Given this list of marker genes MTNAP1, EYA4, FREM1, RIMKLB, LAMC1, GNB4, PCLO, BCAT1, A1CF, ALDH2, C6orf62, CD36, TBL1XR1, SCN2A, GBE1, SLC16A1, ZNF644, TRIP12, KIF1B, SLC17A1, MRO, PPIC, SRP9 (NCBI Gene Id 6726), HUS1, GRM8, RELCH, MSTN, TCF12, FABP7, TMEM64, APC, CDK6, NR2F2 (NCBI Gene Id 7026), MED23, MAPK8, NUB1, ASB14, RALB, CWC27, ZMYM3, PLEKHF2, SMAD2, KLHL15, SHROOM3, USP13, GPC6, COL25A1 (collagen type XXV alpha 1 chain), SEPTIN10, TGFA, PCNX4, TMEM38B, RPRD1A, HMGCLL1, CCDC186, SGIP1, SPATA6L, DBI, ZC3H12C, JMY, NLGN1, MSANTD4, NEGR1 (NCBI Gene Id 257194), NUP54, OLA1 (NCBI Gene Id 89690), PNO1, ACVR1C, PRXL2A, VPS72, MGAT2, ZNF274, PKIA, HAPLN1 (NCBI Gene Id 1404), TPT1 (NCBI Gene Id 7178), OTUD4, TMEM167A, KCNJ2, RAPH1, VAV3, FAM20B, DUSP16, PRLR, UST, N4BP2, ZNF431, KLRC2, CCNE1, DLST, AGA, SPAG9, PERM1, SECTM1, SCN3B, TNFSF14, MYO1D, TSC22D2, PCDH11X, EML1, SLC36A4, LNPEP, SHLD1, TMX3, ZNF507, ABHD2, GEMIN2, IRAK2, GIGYF2, ZC2HC1A, COL22A1, MARK1, RUNX1, CASP1, PDHA1, PRDM5, CDKN1C, PCDHB4, MLF1, TRAPPC10, PTPRN2, P2RY13, SENP2, EXPH5, RAPGEF6, IFNK, PPM1B, CHL1, IRGQ, MMAA, SLC25A24, MGAT1, CNKSR3, C9orf57, CXADR (CXADR Ig-like cell adhesion molecule), RNGTT, FECH, COG6, SLC25A2, TEX26, WDR44, ZNF527, AZIN1, BDH2, SCOC, DDC, PLA2R1, ARL6IP6, CSNK1A1L, ERICH1, CBLN1, DYNLT1, VIRMA, DENND4A, COL3A1, LIMA1, FAM171B, CSRNP3, PIWIL4, KLHL14, C5orf15, CSGALNACT2, DACH1, VWC2, ARHGAP15, MTHFSD, PUM2, ACTA2, PLPP4, MMP16, YIPF6, SASS6, CAPN14, TNFRSF11B, RAB27B, SOCS6 (suppressor of cytokine signaling 6), MAB21L1, VPS45, BOLA2-SMG1P6, SLC35F5, ARIH1, ATG4C, ATP5PB, TRAPPC11, TTPAL, ABCC5, N4BP2L2, ZDHHC15, FANCD2, PDXDC1, MAP1A, CATSPERE, ZC3H14, ESYT2, TTC33, ZNF569, GPR158, TRMT9B, XYLT1 (xylosyltransferase 1), RMC1, MTCP1, PTGER2, DCAF12, ZKSCAN3, GFM2, DSEL, PLCL1, TRIM10, ANKRD20A1, CMC1, GATC (glutamyl-tRNA amidotransferase subunit C), RAB23, NECTIN4, ASXL1 (NCBI Gene Id 23393), ADAM10, NPR3, ZBTB33, MCTP1, DNAH14, DCUN1D4, KCNAB1, BRWD1, EVI2B, RAB11FIP2, ADAM28 (ADAM metallopeptidase domain 28), CLSTN2, MDM4, TM9SF3, SS18L1, TTC27, ATXN3, ZNF516, RNF38, RPA1, UBE2D1, SLC44A1, HEMGN, SNTG1, KATNAL1, PIKFYVE, AGPS, MEGF11, RXFP1, LYSET, TMEM215, MED13L, CERK, RFLNB, ODR4, MSL1 (MSL complex subunit 1), NIPA2, KLF12, PDCD1LG2, VSTM2A, BRWD3, LMLN, ANKRD12, TSHZ3, RALGPS2, FAM114A2, SP140L, HDX, ANKRD42, NAV1, TP53AIP1, SCN7A, ZMYM2, HOOK3, KIAA1549L, CNOT6, SCPEP1, SKIC3, ZBTB20, NCR2, SLC15A2, GAS2L3, NUDT16, ATXN1, ANKRD20A4P, FUT9, ZBTB44, CSAG3, NALCN, LBH, AAK1, TIAM1, CDH13, RAB21, PLK4, MATR3, SMG1, CPXCR1, TAFA2, WIPF1, NXPE3, ADCY9 (adenylate cyclase 9), HDAC9, OTOGL, LEPROT, INO80C, ZNF620, ITPRIPL2, SNUPN, LBR, CSAG1, RYR3, IVNS1ABP, TET2, C11orf87, CNIH1, CALML4, RSF1, STXBP5L, CEP20, EXOC8, AADAC, GLRB, ARV1, SLC19A4P, KCNS3, SIX4, ECHDC3, SLC1A1, CCDC88A, RBBP5, NANP, NECAB1, TAOK1 (NCBI Gene Id 80214), BMPR2, CCDC102B, MAPK10 (NCBI Gene Id 5602), PLPPR4, VCPIP1, TNKS, PDE7A, CDC40, RUNX1T1, MFSD4B, ANKRD20A2P, CHUK, DHX29, PCDH17, MINDY2, MOXD1, here is a description of the gene set: Human Gene Set: MIR3942_3P Genes predicted to be targets of miRBase v22 microRNA hsa-miR-3942-3p in miRDB v6.0 with MirTarget v4 prediction scores > 80 (high confidence targets). species: Homo sapiens from publication Chen Y, Wang X (PMID 31504780)